The following is a description of a gene set: species: Mus musculus Mouse Gene Set: GOCC_ASYMMETRIC_GLUTAMATERGIC_EXCITATORY_SYNAPSE A neuron to neuron synapse with a postsynaptic density, that uses glutamate as a neurotransmitter and whose activity results in excitatory postsynaptic potentials., and this is the list of marker genes: Chd4, Sema3a, Adgrb3, Plxna4, Shisa7, Elavl2 (NCBI Gene Id 15569), Sort1, Grn, Tmem240, Cntnap2, C1ql2, C1ql1, Mgll, Ywhah, Itgb1, Grid2ip, Grm4, Shisa6, Ogt, Plxnc1